The following is a description of a gene set: studied in species Mus musculus from publication Chen Y, Wang X (PMID 31504780) Mouse Gene Set: MIR_6899_3P Genes predicted to be targets of miRBase v22 microRNA mmu_miR_6899_3p in miRDB v6.0 with MirTarget v4 prediction scores > 80 (high confidence targets)., and this is the list of marker genes: Fgf11, Kmt5a, Sumo2, Rbm47, Vcp, Esrrg (estrogen-related receptor gamma), Gm9, Mgat3, Ypel2, Pde3a, Tra2a, Trappc10, Gpr158 (G protein-coupled receptor 158), Sec24b, Synpo2, Scn8a, Adam1b, Pcyt1a, Rsrc2, Zfx (NCBI Gene Id 22766), Zc2hc1a, Aff4, Pla2g6, Layn, Prdm8, Ascl4, Rps6kb1, Ctbp1, Aplnr, Slc7a6, Zc3h6, Hoxb4, Map3k20 (mitogen-activated protein kinase kinase kinase 20), Zic4, Zcchc14, Cept1, Man1a, Tor1b, Ctdspl2, Grip1, Cadm2, G3bp2, Kdm5a, Zfp36l1, Mapkapk3, Htr2c, Enpp4, Aqp1, Cdh11, Sod2, Plekha3, Pnrc2, Pcdh20, Otc, Pou3f4, Erc2, Gpd2, Mbnl1, Zfp420, Cul2, Mslnl, Zfp974, Pi4k2a, Bbs1, Foxred2, Anln, Phex, Map1a, Slc24a2, Zyg11b, Slc16a6, Sertm1, Pld1, Fbxo33, Prtg, Hspb7, Pan3, Mblac2, Hmbox1, Csnk1e, Ube2q1, Bicd1, Chpt1, Zfp91, Cacna1a, Sacs, Aard, Pafah1b1, Arid1a, Ppm1g, Ppp1cb, Ppm1e, Mef2a, Syt1, Stag2, Erap1 (endoplasmic reticulum aminopeptidase 1), Hif3a, Napa, Clec2e, Ereg, Baz2b, Gmpr, Epha7, Pgap2, Pbrm1 (polybromo 1), Irx1, Deptor, Lrat, Il6st, Ssbp3, Gab1, Stxbp6, Npc1